The following is a description of a gene set: species: Mus musculus The process pertaining to the initial formation of an animal organ from unspecified parts. The process begins with the specific processes that contribute to the appearance of the discrete structure, such as inductive events, and ends when the structural rudiment of the organ is recognizable, such as a condensation of mesenchymal cells into the organ rudiment. Organs are a natural part or structure in an animal or a plant, capable of performing some special action (termed its function), which is essential to the life or well-being of the whole. The heart and lungs are organs of animals, and the petal and leaf are organs of plants. In animals the organs are generally made up of several tissues, one of which usually predominates, and determines the principal function of the organ. Mouse Gene Set: GOBP_ANIMAL_ORGAN_FORMATION, and this is the list of marker genes: Dkk1, Wnt5a, Gli2, Gdnf, Ift88, Pim1 (NCBI Gene Id 18712), Tbx5, Pax2, Robo1, Mef2c, Bmp4, Rdh10, Mapk3, Notch1, Bmp7, Gli3, Bmp2, Isl1, Ctnnb1, Tbx1 (T-box 1), Mks1, Wnt2b, Rbm20, Ntf5, Fgf3 (NCBI Gene Id 14174), Trp63, Hoxa3, Rbpj, Cited2, Spry1, Mesp1, Wnt11, Fgf10, Map2k1, Fgf8, Pax3, Hhex, Robo2, Tlx1, Emp2, Folr1, Fgfr2 (NCBI Gene Id 20946), Hoxc11, Lemd2, Hoxa11 (homeobox A11), Fgf1, Pax8, Bmpr1a, Smarcd3, Gng5, Nkx3-2, Gata5, Shh, Eya1, Hand2, Foxh1, Hoxd11, Six1, Fgfr1, Ar (NCBI Gene Id 11835), Tbr1, Frs2, Wnt2, Nog, Axin2, Lrp2, Map2k2, Fgfr4, Wt1, Gata6, Fgf2, Tgfbr2, Sulf1, Mapk1, Ext1, Hes1